Given this list of marker genes SLC16A2, SLC7A8, SLCO4A1, SLC7A5, SLCO1C1, SLCO1B1, SLC16A10, SLC17A4, here is a description of the gene set: Human Gene Set: GOMF_THYROID_HORMONE_TRANSMEMBRANE_TRANSPORTER_ACTIVITY species: Homo sapiens Enables the transfer of thyroid hormones from one side of a membrane to the other. Thyroid hormone are any of the compounds secreted by the thyroid gland, largely thyroxine and triiodothyronine.